The following is a description of a gene set: Normal human colour vision is trichromatic, based on 3 types of cones that are maximally sensitive to light at approximately 420 nm (blue cones), 530 nm (green cones), and 560 nm (red cones). Neural circuits compare light absorbed by these 3 cone types to perceive those primary colours and combinations of them. Colour vision deficiencies result from genetic mutations that affect the expression of the full complement of cone photoreceptors and are classified by severity of deficiency (see reviews Deeb 2005, Simunovic 2010).<br><br>Tritan (blue-yellow, blue colourblindness, tritanopia; MIM:190900) deficiencies are rare (1 in 500) (Went & Pronk 1985) compared to those involving green- and red-cone deficiencies. The first report of tritan defects was in 1952. Tritan deficiencies are inherited as autosomal dominant traits and are a result of missense mutations in the blue-cone photopigment gene OPN1SW, leading to amino-acid substitutions in the protein sequence. Tritan defects are characterized by a selective deficiency of blue spectral sensitivity. Reactome Pathway: Defective visual phototransduction due to OPN1SW loss of function part of: Retinoid cycle disease events studied in species Homo sapiens, and this is the list of marker genes: OPN1SW